The following is a description of a gene set: species: Mus musculus Ketone body metabolism Mouse Gene Set: REACTOME_KETONE_BODY_METABOLISM, and this is the list of marker genes: Hmgcs2, Bdh1, Oxct2a (NCBI Gene Id 64059), Acss3, Oxct2b, Bdh2, Hmgcll1, Aacs, Oxct1, Hmgcl, Acat1 (acetyl-Coenzyme A acetyltransferase 1)